The following is a description of a gene set: Human Gene Set: GOBP_SRP_DEPENDENT_COTRANSLATIONAL_PROTEIN_TARGETING_TO_MEMBRANE_TRANSLOCATION studied in species Homo sapiens The process during cotranslational membrane targeting wherein proteins move across a membrane. SRP and its receptor initiate the transfer of the nascent chain across the endoplasmic reticulum (ER) membrane; they then dissociate from the chain, which is transferred to a set of transmembrane proteins, collectively called the translocon. Once the nascent chain translocon complex is assembled, the elongating chain passes directly from the large ribosomal subunit into the centers of the translocon, a protein-lined channel within the membrane. The growing chain is never exposed to the cytosol and does not fold until it reaches the ER lumen., and this is the list of marker genes: TRAM2, SEC61B, SEC61A2, TRAM1, ZFAND2B, TRAM1L1, SRP54, SEC61A1